Given this list of marker genes CELA3A, SCN1A, KLHL4, XCR1, IL17RE (NCBI Gene Id 132014), NFE2, CASK, CACNA2D3, ITGA2B, EPO, MYO1C, IL6, SLC2A7, RIBC2, CELA3B, MYOT, TPH2, SRPK2, ATXN1, HOXA3, CNMD, SYNE2 (NCBI Gene Id 26075), BRWD3, ZBTB7B, DOK2, GNB1L, PIK3R3, CCDC60, RAI1, ALX1, NR5A2, NDUFA4L2, HESX1, MAP2K7, DIPK2B, DNASE1L3, GJB1, CASZ1, TFCP2, CHRM3, FEV (NCBI Gene Id 54738), HOXA13, CYTH3, POU4F1, IL4, PALM, USP32P2, RRAGA, LMO4, PI15, FSIP2, HOXC4, SYNJ1, IL7, COL4A3, KCNS3, ADCYAP1, ZNF263, PDZD2, RABEP1, HEY1, MGAT4C, PLAC1, PSMA6, GABRA2, SPATS1, LHFPL2, WAPL, HBZ, TLK1, RARB, GATA6, P2RY10, GRIN2B, PTPRR, VSIG1, ANGPTL6, KCNH5, HOXA7, RORB, PNLIPRP2, LIX1, PNLIPRP1, HES1, ZBTB7A, PIGV, BMP10, SLC14A1, GATA4, CXCL6, CRLS1, ZDHHC1, EGR2, SKAP1, MOGAT2, ECT2, ZBTB20, ZFPM2, SCMH1, POM121L1P, VSNL1, UNC45B, HOXB7, PAPPA, RMDN3, LMO2, MAP4K5, RABL6, ANGPT2, ARMC8, USP47, RHAG, COL4A4, STXBP2, UBE3A, RUNX1T1, MYCT1, FAM117A, GPBP1, FILIP1, ENO2, PRG2 (NCBI Gene Id 87065), ARID3B, MTMR10, JUN, GPX1, LEMD1, CACNB3 (calcium voltage-gated channel auxiliary subunit beta 3), NEO1, PON3, IKZF2, SIN3A, SAMD11, ZBTB10, ARHGEF10L, ARHGEF37, HOXA11, ZDHHC22, TLE3, RTL10, MYBPC3, SRSF1, TPM1, BMP7, SEMA4D, KEL, SERTAD4, CNTLN, HOXB6 (homeobox B6), LUC7L3, UBXN10, GNL3LP1, HOXC10, CCDC80 (NCBI Gene Id 151887), CPEB4, GATA1, MSX1, TSC22D3, NEDD4, TYRO3, KRT15, CLVS1, SETD2, UBL3, EPX, PSMA1, RYBP, KRT2 (NCBI Gene Id 3849), CAST, PLAGL1, SMC1B, EN1, PCDH9, DMTN, RNF186, TMEM47, TAFA1 (NCBI Gene Id 494552), HINT1, C4orf50, C12orf42, TGIF2 (NCBI Gene Id 60436), PTPRG (protein tyrosine phosphatase receptor type G), KCNJ15, ESRRB, SLC25A12, NKX6-2 (NCBI Gene Id 84504), MAF, TBX4, SOX5, SENP8, FOXP2, HOXD12, ABCF3, ERG, ZFPM1, TMEM132A, PUM2, TNRC6A, KCTD6, AMOT, STC1, MECOM, PDE3B, RSBN1L, HEMGN, PITX2, NFRKB (NCBI Gene Id 94689), PDGFA, GSK3B, ALDH1A1, SLC18A1, CLDN7, DIS3L, RGS1, CLEC1B, TAB2, FLI1, ETV1, CAVIN2, CDH2, BDNF, ICAM2 (intercellular adhesion molecule 2), NEUROG3, RREB1, KLF12, RBFOX2 (RNA binding fox-1 homolog 2), CALM2, CPNE1 (NCBI Gene Id 8904), SLC10A7, ELAVL4, HIC1, TWIST1, TRPS1, PDZRN4, LRRTM3, TGFB2, NDP, PPP1R16A, SULF1, TSPEAR, SEC16B, CREB5, ESRRA, PTPN12, CTCF, TMEM86B, LINC00656, POU4F2, CCL18 (NCBI Gene Id 6362), SLC25A25, SYT16, SOBP, FOXA1, EGFL7, LMTK2, NR2F2 (NCBI Gene Id 7026), NECTIN1, NR3C1, CXCL5, OTX2, CA9, FERMT2, KLF5, SMAD3, CD40, ALPK2, CTNNA3, RFESD (Rieske Fe-S domain containing), ADGRG6, CSRNP3 (cysteine and serine rich nuclear protein 3), FAM72A, PHF21A, C5orf46, WDR5B, IP6K2, CEBPB, SFRP1, TSHB, LHX6, HS3ST5, PLEKHA1, ZIC1, GUCA2A, ID3, ANXA13, here is a description of the gene set: Human Gene Set: GATA1_05 species: Homo sapiens Genes having at least one occurrence of the motif NCWGATAACA in the regions spanning 4 kb centered on their transcription starting sites. This matches the GATA1 transcription factor binding site V$GATA1_05 (v7.4 TRANSFAC).